The following is a description of a gene set: Reactome Pathway: Chk1/Chk2(Cds1) mediated inactivation of Cyclin B:Cdk1 complex studied in species Homo sapiens part of: G2/M DNA damage checkpoint DNA damage induced activation of the checkpoint kinases Chk1/Chk2(Cds1) results in the conversion and/or maintenance of CyclinB:Cdc2 complex in its Tyrosine 15 phosphorylated (inactive) state. Cdc2 activity is regulated by a balance between the phosphorylation and dephosphorylation by the Wee1/Myt1 kinase and Cdc25 phosphatase. Inactivation of the Cyclin B:Cdc2 complex likely involves both inactivation of Cdc25 and/or stimulation of Wee1/Myt1 kinase activity., and this is the list of marker genes: CCNB1, YWHAH, WEE1 (NCBI Gene Id 7465, WEE1 G2 checkpoint kinase), CHEK1, CCNA2, CDK1, YWHAE, CDC25C (NCBI Gene Id 995), YWHAQ, CHEK2 (NCBI Gene Id 11200), YWHAG, YWHAZ, YWHAB, SFN, CCNA1